The following is a description of a gene set: species: Mus musculus Mouse Gene Set: GOCC_CYTOPLASMIC_MICROTUBULE Any microtubule in the cytoplasm of a cell., and this is the list of marker genes: Tpt1 (NCBI Gene Id 22070), Spag8, Cyp2a5, Kif18b, Togaram1, Efcab6, Gtse1, Cimip2c, Cimap1d, Trpv4, Gramd2b, Sctr, Mapre3, Spmip9, Fam161b, Cimip2b, Misp, Mapre2, Tmem214, Tuba1b (NCBI Gene Id 22143), Fhdc1, Fbxw11, Cfap77, Tekt3 (NCBI Gene Id 71062), Cfap126, Enkur, Map10, Bcas3, Cfap90, Saa1, Tubg2, Dusp21, Cfap144, Spaca9, Synj2 (NCBI Gene Id 20975), Mid1, Reep3, Tekt1, Reep1, Snph, Clip2, Pierce1, Cyld, Arl6, Cimip2a, Spmip8, Spmip6, Nin, Clasp1 (NCBI Gene Id 76707), Cfap68, Spmip11, Bysl, Kif18a, Tubg1, Cfap161, Bcl10, Kif2c, Apc, Efhc2, Ift70b, Dcxr, Saxo1, Cfap141, Tekt4, Cfap20, Saa2, Ribc1, Nme7, Selenos, Dnai7, Cfap45, Spmip5 (sperm microtubule inner protein 5), Tuba1c, Arl3, Pde4dip, Cfap276, Tektl1, Cfap52, Reep4, Pacrg, Dynlt3, Tekt5, Tekt2, Efhb, Ribc2 (NCBI Gene Id 67747), Arfgef2, Ift70a2 (intraflagellar transport 70A2), Saxo4, Clmp, Clasp2, Pafah1b1, Apc2, Mapre1, Numa1, Clip1, Dync1h1, Enkd1, Birc5, Cfap210, Rab3d, Sybu, Arhgap18, Srprb, Ift70a1, Bicd1, Pierce2, Cyp2a4, Mtus2, Serp1, Map9, Mns1, Ccsap, Cep162, Cfap53, Saxo2 (NCBI Gene Id 67368), Efhc1, Fam161a, Rpgrip1l (Rpgrip1-like), Tubb4b, Cfap96, Cfap107, Hid1, Spmip10, Cfap206, Togaram2, Cfap95, Tektip1, Tuba1a, Reep2